Given this list of marker genes Kif15, Mos, Efhc1, Rnf4, Haus5, Ankrd53, Ccdc61, Smc3, Aurka, Chmp1b2, Rae1, Fbxo5, Nup62, Dctn6, Knstrn, Stag1, Cep97, Nuf2, Chmp4b, Cep192, Tacc1, Tbce, Dlgap5, Tacc2, Cenpj, Lzts2 (NCBI Gene Id 226154), Gtf2b, Dctn2, Haus6, Rhoa, Hnrnpu (NCBI Gene Id 98724), Chmp1a, Ccdc66, Cep126, Haus4, Cltc, Mybl2, Kif2a, Aunip, Bccip, Spast, Fam110a, Wdr62, Ranbp1, Arhgef10, Ofd1, Plk3, Birc5, Washc1, Cdc20, Rps3, Cdca8, Tubgcp2, Ntmt1, Cenph, Myh9, Kifc5b, Sass6, Prc1, Tpx2, Nudc, Zfp207, Mlh1, Gpsm2, Fsd1, Chmp7, Gnai1, Kif3b, Map9, Ripor2, Plk5, Kif23, Rgs14, Aurkb, Ccnb1, Psrc1, Stag2, Pibf1, Haus2, Ddb1, Rab11a, Ccnb1-ps, Dicer1, Ska1, Afg2b, Mapre1, Prickle1, Spc25, Poldip2, Trim36, Chek2, Poc1a, Tubgcp6, Mapre2, Wrap73, Limk2, Kiz, Ccsap, Ckap5, Hdac3, Cep120, Misp, Stmn1, Haus7, Pcnt, Eml1, Bcas2, Chmp5, Chmp3, Map1s, Kifc1 (NCBI Gene Id 21656), Senp6, Dlg1, Cep72, Lsm14a, Rangrf, Khdc3, Aurkc, Kash5, Ilk, Parp3, Ints13, Ppp2r1b, Tubgcp3, Pde4dip, Kpnb1, Clasp1, Bora, Dcaf13, Ezr, Tubg2, Tppp, Ccdc69, Sac3d1, Chmp6, Aspm, Ptpa, Map10, Ppp2r1a, Rcc1, Mapre3, Kif11, Dync1h1 (dynein cytoplasmic 1 heavy chain 1), Chmp4c, Aaas, Ndc80, Sugt1, Washc5, Abraxas2, Mzt1, Plk1, Incenp, Tubgcp4, Pten, Haus8, Eml3, Ino80, Ncor1, Mei1, Numa1, Chd3, Ska2, Espl1, Kif4, Racgap1, Snhg15, Cenpe, Cep63, Chmp2a, Nek2, Golga2, Tubgcp5, Chmp1b, Abraxas1, Plk2, Septin1, Ccnb2, Uvrag, Tubb5, Stard9, Vps4b, Spice1, Haus3, Smc1a, Map4, Tubb1, Dctn1, Ska3, Pkd1, Uhrf1, Csnk1d, Hspa1a, Flna, Tubg1, Chmp2b, Spag5, Tpr, Mapk15, Drg1, Clasp2, Sbds, Haus1, Tacc3, Atrx, Stil, Hspa1b, Vcp, here is a description of the gene set: A process that is carried out at the cellular level which results in the assembly, arrangement of constituent parts, or disassembly of the spindle, the array of microtubules and associated molecules that forms between opposite poles of a eukaryotic cell during DNA segregation and serves to move the duplicated chromosomes apart. species: Mus musculus Mouse Gene Set: GOBP_SPINDLE_ORGANIZATION